The following is a description of a gene set: species: Homo sapiens Down-regulated in ovarian epithelial cells (MCV152) 72 hours following FSH treatment, compared to untreated Human Gene Set: JI_RESPONSE_TO_FSH_DN Epidemiologic data have implicated reproductive follicle-stimulating hormone (FSH) as a probable risk factor for ovarian cancer (OC) development. Although pituitary and sex hormones have been reported to regulate OC cell growth, no information is available on the influence of FSH on gene expression profiles during ovarian surface epithelial (OSE) cell proliferation. This study evaluated the effect of FSH treatment on cell proliferation of various OSE cell lines and gene expression profiles with FSH treatment. Follicle-stimulating hormone receptor (FSHR) was found at higher expression at both transcriptional and protein levels in ovarian cancerous tissues compared to normal tissues, and FSH was shown to promote cell growth in 3 OSE cell lines. Furthermore, it was also found that overexpression of FSHR in Chinese hamster ovary (CHO) cells leads to cell proliferation. Using cDNA MicroArray analysis on MCV152 cells with FSH treatment, genes were found upregulated and genes downregulated for more than 2-fold after FSH treatment. Most of the genes were related to metabolism, cell proliferation and oncogenes. Downregulated genes included tumor suppressor genes (RB1, BRCA1, BS69) and the genes related to cell proliferation control. Pathway analysis found that FSH activates certain important enzymes in sterol biosynthesis pathways. FSH-induced gene expression profiles on MCV152 cells support the standing hypothesis that FSH is a probable risk factor for ovarian cancerous development. from publication Ji Q, Liu PI, Chen PK, Aoyama C (PMID 15386376), and this is the list of marker genes: RRM2 (ribonucleotide reductase regulatory subunit M2), TOP2B, KIF5B, ADD1, ATP5F1A, MAP2K1, PRPS1, RB1, PITPNB, CYB5B, DUSP1, PAK2, FN1, CDK8, RAF1, MAT2A, PLEC, VCAN, SERPINE1, GNA13 (G protein subunit alpha 13), ARF6, UBE2G1, SNAP23, TOP2A, YWHAZ, CALR, EIF2S3, MAGI2, EMP1, FGF2, ITGA6, ZMYND11, ASPH, TOP1, ARHGAP5, PRP4K, DDX3X, SERBP1, RAB6A, PACSIN2 (NCBI Gene Id 150377), JAK1, GDI2, OSMR, RANBP9, CCNF, GNS, TFDP1, BRCA1, PANK3, GPR176, MED6, UBA52, FGF5